The following is a description of a gene set: Any process that results in a change in state or activity of a cell or an organism (in terms of movement, secretion, enzyme production, gene expression, etc.) as a result of a stimulus indicating deprivation of sterols. Sterols are a group of steroids characterized by the presence of one or more hydroxyl groups and a hydrocarbon side-chain in the molecule. Human Gene Set: GOBP_RESPONSE_TO_STEROL_DEPLETION studied in species Homo sapiens, and this is the list of marker genes: LYN, TMED2, INSIG2, ARHGEF10L, ERLIN1, PIP4P1, EIF2A, SCAP, INSIG1, SPRING1, SREBF1, ZBTB7B (zinc finger and BTB domain containing 7B), MIR96 (NCBI Gene Id 407053), ERLIN2, FBXW7, NPC1L1, PAQR3, SREBF2, AMFR (autocrine motility factor receptor)